Given this list of marker genes RFC5, PCNA, POLE4, POLE3, UBB, UBA52, POLE2, RFC4, LIG3, RFC3, UBC, POLD3, RPS27A, XRCC1, POLD4, POLD1, POLK, RPA2, RFC1, RFC2, LIG1, POLD2, POLE, RPA3, RPA1 (NCBI Gene Id 6117), here is a description of the gene set: Human Gene Set: REACTOME_GAP_FILLING_DNA_REPAIR_SYNTHESIS_AND_LIGATION_IN_GG_NER species: Homo sapiens Gap-filling DNA repair synthesis and ligation in GG-NER